The following is a description of a gene set: Mouse Gene Set: chr14B species: Mus musculus, and this is the list of marker genes: Gm25204, Gm9671, Ldb3, Dph3, Gm7954, Gpr15lg, Itih1, Gm3486, Gm9611, Gm8138 (NCBI Gene Id 666502), Gm9732, Frmpd2, Sfmbt1, Gm6536, Actr8, Gm19129, Cacna1d, Gm3008, Gm24998, Mat1a, Spcs1, Phf7, Dydc1, Gm53218, Fam25a, 1700049E17Rik1, Gm19016, Il17rb, Snord19, Gm3025, Cdhr1, Gm2791, 1700049E17Rik2, Gm8126, Gm30083, Nt5dc2, Gm17124, Gm28651 (predicted gene 28651), Gm7644, Cdv3-ps, Gm47189, Mapk8, Gm5929, 3425401B19Rik, Gm7925 (NCBI Gene Id 666093), Gm7853, Gm4817, Ncoa4, Glt8d1, Gm7621, Sh2d4b, Bap1, Gm25498, Gm23909, Gm24394 (predicted gene, 24394), Gm26228, Gm18909 (predicted gene, 18909), Nrg3os, Itih3, Parg, Tspan14 (NCBI Gene Id 52588), Gm8020, Gm18760, Gm17940, Gm3111, Eaf1, Wapl, Wdfy4, Ercc6, Gm17026, Slc18a3, D830044D21Rik, Gm9890, Gm2966, Gm24916, Gm3102, Gm31393, Sftpa1, Gm7951, Mir346, Oxnad1, 1700091H14Rik (RIKEN cDNA 1700091H14 gene), Syt15, 1700001F09Rik, A630023A22Rik, Gm35823, Gm46474, Mmrn2, 4930474N05Rik, Gm8068, Colq, Gm7945, Nek4, Vstm4, Ptpn20, Gm2959, Sncg (NCBI Gene Id 30871), A930038B10Rik, Pbrm1, Gm8114, Gm20642, Shld2, Gm18834, Gm7980, Gm21977, Gm6482, Mustn1 (musculoskeletal, embryonic nuclear protein 1), Gm2878, Glud1, Gm3573, Mbl1, Gm23946, Galnt15, Gm8104, Gm3676, Gm2951, Gm8127, Gm7707, Gm7233, Arhgap22, 9230112D13Rik (RIKEN cDNA 9230112D13 gene), Gm35389, Gm5204, Tnnc1, Gm17027, 1700109I08Rik, Gm18681, Drgx, Capn7, Gm6340, Snord69, Gm8065, Gm5460, Tkt, Sftpd, Grid1, Msmb, 1700024G13Rik, Mir3076, Gm7734, Timm23, Gm9597, Rgr, 4930503F20Rik, Gm2990, Ogdhl, Gm2832, Btd, 5830448L01Rik, Gdf10, Itih4, Gm17210, Sema3g, Sh3bp5, Gm18072, Gm7953, Gm5203, 1700087M22Rik, Gm49252, Gm49040, 4930425P05Rik (NCBI Gene Id 73882), Uqcc5, Nisch, Gprin2, Gm7316 (NCBI Gene Id 640992), Gm3219, Stimate, Ghitm, Gm5798, Gm3015, Gm8122, Mir6947, Gm5459, Gm7970, Rpl23a-ps3, Gm7778, Gm3123, Ccser2, Ankrd28, Gm22469, Gm8024, Gm7991, Gm49141, Gm7152, Antxrl, Gm15667, Gm7995, Bmpr1a, Gnl3 (guanine nucleotide binding protein nucleolar 3), Opn4 (NCBI Gene Id 30044), Gm7920 (NCBI Gene Id 676270), Rbp3, Gm5205, Gm18523 (NCBI Gene Id 100417312), Gm10376, Gm46447, Lrrc18, Gm18813, Gm47547, Gm3141, Gm18884, Gm3543, Tmem273, Gm46448, Dcp1a, Gm8032, Gm3077, Gm10377 (predicted gene 10377), Gm31456, Mettl6, Dnah1, Npy4r, Gm30556, 4930596D02Rik, Lrit1, Chat, Gm8094, 1700024B05Rik, Dydc2, Gm6490, Lrit2, Prkcd, Eif1-ps1, Rft1, Gm8005, Gm7929, Zfp488, Gdf2, Chdh, Gm3633, Stab1, Anxa8, Gm3072, Gm2930, Nrg3, Gm6401, Prxl2a, Gm2855, Fam170b, Hacl1